Given this list of marker genes GATA5, FGFRL1, MDM2, ZFPM1, GATA4, NOS3, SOX9, NAGLU, EFNA1, NOTCH1, SNAI1, GJA5, MEF2C, BMP4, ROCK2, TBX5, SCX, BMPR2, SMAD4, ROBO1, TGFBR2, SMAD6, MDM4, ACVR1, OLFM1, BMP2, RHOA, RB1, DCHS1, SLIT3, TIE1, BMPR1A, MTOR, SLIT2, NOTCH2, ROCK1, JAG1, AXIN2, CCN1, ADAMTS19, ADAMTS5, EMILIN1, HEY1, CDH11, TGFB1, STRA6, FAM114A1, DLL4, NFATC1, NKX2-5, GATA3, SOX4, SMAD2, ADAMTS9, ROBO2, HEYL, ELN, HEY2, NPPA, TGFB2, TBX20, TWIST1, SNAI2, here is a description of the gene set: studied in species Homo sapiens Human Gene Set: GOBP_HEART_VALVE_MORPHOGENESIS The process in which the structure of a heart valve is generated and organized.